The following is a description of a gene set: Human Gene Set: REACTOME_FORMATION_OF_THE_NON_CANONICAL_BAF_NCBAF_COMPLEX species: Homo sapiens Formation of the non-canonical BAF (ncBAF) complex, and this is the list of marker genes: SMARCD3, BCL7A, SMARCD1, BRD9, ACTB, SS18, SMARCC1, BICRAL, BICRA, BCL7C, SMARCD2, BCL7B, SMARCA2, SMARCC2, ACTL6A, SS18L1 (NCBI Gene Id 26039), SMARCA4